The following is a description of a gene set: Genes up-regulated in hematopoietic precursor cells conditionally expressing HOXA9 and MEIS1. from publication Hess JL, Bittner CB, Zeisig DT, Bach C, Fuchs U, Borkhardt A, Frampton J, Slany RK (PMID 16507773) Abdominal-type HoxA genes in combination with Meis1 are well-documented on-cogenes in various leukemias but it is unclear how they exert their transforming function. Here we used a system of conditional transformation by an inducible mixed lineage leukemia-eleven-nineteen leukemia (MLL-ENL) oncoprotein to overexpress Hoxa9 and Meis1 in primary hematopoietic cells. Arrays identified c-Myb and a c-Myb target (Gstm1) among the genes with the strongest response to Hoxa9/Meis1. c-Myb overexpression was verified by Northern blot and quantitative reverse transcription-polymerase chain reaction (RT-PCR). Also MLL-ENL activated c-Myb through up-regulation of Hoxa9 and Meis1. Consequently, short-term suppression of c-Myb by small inhibitory RNA (siRNA) efficiently inhibited transformation by MLL-ENL but did not impair transformation by transcription factor E2A-hepatic leukemia factor (E2A-HLF). The anti c-Myb siRNA effect was abrogated by coexpression of a c-Myb derivative with a mutated siRNA target site. The introduction of a dominant-negative c-Myb mutant had a similar but weaker effect on MLL-ENL-mediated transformation. Hematopoietic precursors from mice homozygous for a hypo-morphic c-Myb allele were more severely affected and could be transformed neither by MLL-ENL nor by E2A-HLF. Ectopic expression of c-Myb induced a differentiation block but c-Myb alone was not transforming in a replating assay similar to Hoxa9/Meis1. These results suggest that c-Myb is essential but not sufficient for Hoxa9/Meis1 mediated transformation. Human Gene Set: HESS_TARGETS_OF_HOXA9_AND_MEIS1_UP species: Mus musculus, and this is the list of marker genes: SNRPA1, BID, YBX3, IMMT, ICAM2, NEDD4, CD28, ENTPD4, BET1, RUVBL1, NOP58, WEE1, NCL, GSTM5, TRIP13, ODC1, MCM3, GAS5, MRPL15, RRM1, DTYMK, LIN28A, HOXA9, PDE7A, IDE, KLF9, FABP5, PRMT1, PSMG2, RHOJ, CLDN15, MYB, BCAT1, HDAC2, PPID, MCM3AP, PHGDH, PPAN, CEBPA, DNAJA3, ASNS, C1QBP, SCHIP1, HMGCR, GOT1, DUT, MYBL2, GABPB1, MSH2, SLC26A6, METAP2, CDC45, TP53BP1, PINX1, NUCB2, GLUD1, TST, RRS1, UHRF1, NOLC1, AFP, MCM7, CTPS1, TFAP4, IFRD2, MUC13, TRMT2A, RUVBL2, MYLK